Given this list of marker genes Cd24a, Mr1, Hspd1, Crtam (cytotoxic and regulatory T cell molecule), Raet1d, Gsdme, Klrk1 (killer cell lectin-like receptor subfamily K, member 1), Prkaa1, Cd226, Hrg, Ywhag, Slc22a13, Cd160, Il12a, Nectin2, Fbxo38, Pvr, Xcl1, Klhl22, Ulbp1, Il12b, Cd40lg, here is a description of the gene set: species: Mus musculus Any process that activates or increases the frequency, rate, or extent of a response to tumor cell. Mouse Gene Set: GOBP_POSITIVE_REGULATION_OF_RESPONSE_TO_TUMOR_CELL